The following is a description of a gene set: studied in species Mus musculus Mouse Gene Set: chr3A3, and this is the list of marker genes: Fxr1, Mecom, Slc7a14, Gm38509, Dnajc19, Mynn, Spin3-ps, Mecomos, Nlgn1, Gm7733, Actrt3, 4930502C17Rik, Gm6505, Sec62, A830092H15Rik, Gm33206 (NCBI Gene Id 102636014), Mir7008, 1600017P15Rik, Gm18493, Tnik, Gm26040, Gm26354, Gm5845, Gm15496, Gm6558, Gm10259, Naaladl2, Rprl2, Gm9791, Ccdc39, Phc3, 7530428D23Rik, Gm6197, Usp13, Gm31466, Gm37636, Tbl1xr1, Gm24704, Gm2979, Gm15462, Lrriq4, Actl6a, Gm25152, Cldn11, Gm10258, Gm24780, Gm1527, Nceh1, Gm5708, Mir466q, Kcnmb3, Gm42196, Gm7488, 4933429H19Rik, Gm3143, Mir551b (NCBI Gene Id 791072), 9530022L04Rik, Sox2, 1700017M07Rik, Ndufb5, Mrpl47, 1700112D23Rik, Gm4855, Gm33051, Ect2, Gm37191, 4930419G24Rik, Skil, Tnfsf10, Slc2a2, Mannr, Sox2ot, Kcnmb2, Gpr160, Gm23214, 1700125G22Rik, Lrrc31, Pex5l, Gm42205, Gm38505, 4930412E21Rik, Mir6378, Gm21388, Pik3ca, Mir3092, Gm20515, Egfem1, Gm18491 (NCBI Gene Id 100417265), Spata16, Eif5a2, Samd7, Rpl22l1, Pld1, Mir1897, Gm5842, Ghsr, Gm18611 (NCBI Gene Id 100417436), Gnb4, Mfn1, Fndc3b, Lrrc34, Ube2l3-ps1, Zmat3, 4930431L21Rik, Zfp639, Gm7558, Tmem212, Gm17935, Gm19445, Prkci, Mir21b, Ttc14, Gm32950, Gm37770, Gm7536, Gm31693